The following is a description of a gene set: Any process that activates or increases the frequency, rate or extent of establishment or extent of a membrane potential, the electric potential existing across any membrane arising from charges in the membrane itself and from the charges present in the media on either side of the membrane. species: Homo sapiens Human Gene Set: GOBP_POSITIVE_REGULATION_OF_MEMBRANE_POTENTIAL, and this is the list of marker genes: VCP, NDUFC2, SLC34A1, NNT, GLRX, GRIA1, MTLN, MFN1, PRKN, UCN3, BID, BAD, ANK3